Given this list of marker genes GIGYF2, VGLL3, RGS7, AZIN1, IFFO2, ADD2 (adducin 2), NARS1, HRH4, QSOX2, ADAMTS19, PAN2, BMPR1B, UGT1A4, USP7, ATP13A4, ZNF318, STX6, UNC5D, SUMO1, IRF6, KDM5A, RORC, HDGFL3, MAEA (macrophage erythroblast attacher, E3 ubiquitin ligase), STK26, MAPK14, SNCA, CCDC28A-AS1, TNFRSF19, ALG2, DMAC2, UGT2B17, PAPSS1, UGT1A6, ARL15, SLC6A16, RDX, SMNDC1, PRKRA, PDLIM5, ADRA1A, UGT1A5, SSR1, SLC23A2, DYNC1LI2, TMEM167A, CBLN2, PSMC2, CTTNBP2NL, MFAP3, RAB6B, LRRN3, TEX35, H2AZ1, DCTN3, TTPAL (alpha tocopherol transfer protein like), RIMS1, PLCD4, SGK2, CDC40, SCOC, RRAGA, SYT1, APELA, KCNRG, BTN2A2, MARF1, CLEC1A, ATP2B1, ADGRD1, ARHGAP39, NEPRO, WDCP, PRP4K, MAP6, UGT1A7, NFAT5, RAB27B, RORA, PLEKHF1, ANKRD24, AKIRIN2, MYSM1, ABCA12, CALN1, BCL11B, LEF1, WDR7, HDAC2, ZNF207, KRTAP19-6, FOXO3, MARK1, TMEM178B (transmembrane protein 178B), FBXW11, APPL1, HLA-DPB1, PPP1R10 (NCBI Gene Id 5514), PPP1R15B, DIPK1A, WT1, LGALSL, UGT1A3, FAS, SYNPO2L, SATB2, HCFC2 (NCBI Gene Id 29915), TMEM258, CCDC6, FIBIN, HIGD1A (HIG1 hypoxia inducible domain family member 1A), APOBEC3A, ADGRF5, MYO16, IGSF21, FGF13, EXD2, GREM1, UGT1A1, TFCP2L1, NUF2, OTUD5, AAK1, GRSF1, MED13, RALA, BOLL, GOPC, BAZ2B, UGT1A10, AKAP13, RAPH1, YWHAZ, GFRA2, ZNF22-AS1, MIA3, RHEB, DAZAP1, MOBP, THAP6, YPEL1, SELENBP1, NALCN, NCOA1, SLC6A2, NOL4L, FAM13A, HAPSTR1, GNG12, UGT1A9, ROBO1 (roundabout guidance receptor 1), CD164, SCN8A, NUP50, PPHLN1, UQCR10, DCUN1D1 (NCBI Gene Id 54165), NWD1, UGT1A8, ONECUT2, GATM, BTN2A1, ZNF398, MYH9, here is a description of the gene set: Human Gene Set: MIR4786_3P species: Homo sapiens from publication Chen Y, Wang X (PMID 31504780) Genes predicted to be targets of miRBase v22 microRNA hsa-miR-4786-3p in miRDB v6.0 with MirTarget v4 prediction scores > 80 (high confidence targets).